Given this list of marker genes UBTFL6, TAF1B, TBP, RRN3, SMARCB1, UBTFL1, UBTF, BAZ2A, POLR1E, TAF1C, SMARCA4, here is a description of the gene set: studied in species Homo sapiens The formation of a large multiprotein-DNA complex that self-assembles on gene promoter through the sequential recruitment of the general initiation factors that compose the preinitiation complex (PIC) (which includes including UBF, SL1, RRN3 and TBP in human). The PIC engages RNA polymerase I on its DNA template strand and sparks polymerization of the first few RNA nucleotides. Human Gene Set: GOBP_RNA_POLYMERASE_I_PREINITIATION_COMPLEX_ASSEMBLY